The following is a description of a gene set: species: Homo sapiens Stabilization of p53 Human Gene Set: REACTOME_STABILIZATION_OF_P53, and this is the list of marker genes: PSMC6, CDKN2A, PSMB4, UBB, PSMD2, PSMA3, RPS27A (NCBI Gene Id 6233), PSMB6 (proteasome 20S subunit beta 6), PSMB7, PSMB2, SEM1, PSMC3, PSMA7, MDM2, PSMB1, PSMA1, MDM4, UBC, COP1, PSMD6, PSMA2, ADRM1, PSMA5, PSMC1, PSMC2, PSMB3, PSMD12, PSMA6, PSMD11, UBA52, CHEK2, PSMC5, PSMD14, PSMD13, PSMB5, PSMD3, PSMA4, PSMD8, PSMD1, ATM, TP53, PSMD7, PHF20, PSMC4